Given this list of marker genes Akr1cl, Akr1c18, Akr1c6, Akr1c12, Akr1b1, Cbr4, Akr1a1, Akr1c20, Akr1c19, Akr1c13, Akr1c21, Akr1c14, here is a description of the gene set: Mouse Gene Set: GOBP_POLYKETIDE_METABOLIC_PROCESS studied in species Mus musculus The chemical reactions and pathways involving polyketides, any of a diverse group of natural products synthesized via linear poly-beta-ketones, which are themselves formed by repetitive head-to-tail addition of acetyl (or substituted acetyl) units indirectly derived from acetate (or a substituted acetate) by a mechanism similar to that for fatty acid biosynthesis but without the intermediate reductive steps.